The following is a description of a gene set: Abnormality of the distal phalanx of the hallux Human Gene Set: HP_ABNORMALITY_OF_THE_DISTAL_PHALANX_OF_THE_HALLUX species: Homo sapiens, and this is the list of marker genes: TWIST1, TBR1, FGFR1, FIG4, PTHLH, VAC14, NR4A2, MAP3K20, FGFR3, HOXD13, FGFR2, CANT1